The following is a description of a gene set: studied in species Homo sapiens 16p11.2 proximal deletion syndrome Human Gene Set: WP_16P112_PROXIMAL_DELETION_SYNDROME, and this is the list of marker genes: MAP2K3, MAZ, UNC13B, HIRIP3, HDAC3, PCNA, MIR3680-1, PPP4R2, PPARG, CCDC6, PPP4R1 (protein phosphatase 4 regulatory subunit 1), MAPK3, NR3C1, ZG16, PPP4C, KCTD13, CORO1A, CCT7, KMT2D, ASPHD1, MIR3680-2, PARP4, EZR, CASP8 (NCBI Gene Id 841), CCT3, GDPD3, PPP2R1A, CCT4, CCT5, SEZ6L2, TMEM219, TBX6, ESR1, INO80E (INO80 complex subunit E), PPP2CB, PPP4R3A, C16orf92, PPP2R5D, PPP2CA, UNC13A, MVP, YPEL3, REL, TRAF2, PTEN, TAOK2, CCT6A, ALDOA, IGBP1, MAP2K6, TCP1, PPP4R3B, PRRT2, CCT6B, MSN, PPP4R4, IGFBP3, SPN, CDIPT, BPTF, C16orf54, TRAF6, PAXIP1, TP53, KMT2C, PPP4R3C, CCT8, QPRT, SIAH1, KIF22, TLCD3B, NFKB1, HIRA, DOC2A, CCT2, PAGR1